Given this list of marker genes UBC, CREBBP, HEY1, PSEN2, KAT2B, HDAC4, MAML3, HDAC11, MAML1, HDAC1, APH1A, HES5, PSENEN, HDAC5, EP300, RPS27A, SKP1, HDAC6, KAT2A, MAMLD1, CUL1, NOTCH1, FBXW7, DLL4, JAG2, MAML2, PSEN1, HDAC2, NCOR2, RBPJ, CCNC, TBL1XR1, HDAC10, UBB (NCBI Gene Id 91253), RBX1, UBA52, HDAC7, NCOR1, SNW1, CDK8, HDAC9, JAG1, MIB2, HDAC3, MIB1, NCSTN, APH1B, HES1, HEYL, NEURL1, HDAC8, ADAM17, HEY2, ADAM10, TBL1X, NEURL1B, DLL1, MYC, here is a description of the gene set: Reactome Pathway: Signaling by NOTCH1 in Cancer part of: Diseases of signal transduction by growth factor receptors and second messengers species: Homo sapiens Human NOTCH1 was cloned as a chromosome 9 gene, translocated to the T-cell beta receptor (TCBR) promoter on chromosome 7 in T-cell acute lymphoblastic leukemia (T-ALL). This translocation, present in only a small percentage of T-ALL patients, results in the overexpression of a truncated NOTCH1 receptor, which lacks almost the entire extracellular domain, in T lymphocytes. Oncogenic NOTCH1 mutations were subsequently found to be present in >50% of T-ALL patients, with hotspots in the heterodimerization domain (HD domain) and PEST domain of NOTCH1. <br><br>Normal NOTCH1 becomes activated by binding DLL (DLL1 or DLL4) or JAG (JAG1 or JAG2) ligands expressed on the surface of a neighboring cell, which leads to proteolytic cleavage of NOTCH1 by ADAM10/17 and gamma-secretase, and release of the NOTCH1 intracellular domain (NICD1) which regulates expression of genes that play important roles in the development of T lymphocytes (Washburn et al. 1997. Radtke et al. 1999, Maillard et al. 2004, Sambandam et al. 2005, Tan et al. 2005). Mutations in the HD domain, responsible for association of NOTCH1 extracellular and transmembrane regions after furin-mediated cleavage of NOTCH1 precursor, as well as the truncation of the NOTCH1 extracellular domain by the rare T-ALL translocation, enable constitutive production of NICD1, in the absence of ligand binding.<br><br>Mutations in the NOTCH1 PEST domain interfere with FBXW7 (FBW7)-mediated ubiquitination and degradation of NICD1, resulting in prolonged half-life and increased transcriptional activity of NICD1, which promotes growth and division of T-lymphocytes.<br><br>Mutations in the HD domain and PEST domain of NOTCH1 are frequently found in cis in T-ALL. While HD mutations alone result in up to ~10-fold increase in NOTCH1 transcriptional activity and PEST domain mutations alone result in up to ~2-fold increase in NOTCH1 transcriptional activity, in cis mutations of HD and PEST domains act synergistically, increasing NOTCH1 transcriptional activity up to ~40-fold.<br><br>FBXW7 (FBW7), a component of the SCF (SKP1, CUL1, and F-box protein) ubiquitin ligase complex SCF-FBW7 involved in the degradation of NOTCH1, is subject to loss of function mutations in T-ALL which are mutually exclusive with NOTCH1 PEST domain mutations.<br><br>Although gamma-secretase inhibitors (GSIs) are successfully used in vitro to inhibit NOTCH1 signaling in T-ALL cell lines, the gamma-secretase complex has many other substrates besides NOTCH. The specificity of GSIs is therefore limited and, as they are not considered to be particularly promising drugs for the clinical treatment of T-ALL, they have not been annotated.<br><br>For a recent review of NOTCH1 signaling in cancer, please refer to Grabher et al. 2006.